Given this list of marker genes CYLD (NCBI Gene Id 8010), UBE2V1, UBC (NCBI Gene Id 7316), CASP9, TAB1, RPS27A, MAP2K6, CASP1, AAMP, TRAF6, NOD1, TAB3, IKBKG, CARD9, BIRC3, UBE2N, ITCH, MAPK14, MAPK12, MAP3K7, CHUK, BIRC2, MAPK11, IRAK2, IRAK1, CASP2, UBB, UBA52, TNFAIP3, CASP4, IKBKB, CASP8, RIPK2, TAB2, MAPK13, NOD2, here is a description of the gene set: NOD1/2 Signaling Pathway Human Gene Set: REACTOME_NOD1_2_SIGNALING_PATHWAY studied in species Homo sapiens